The following is a description of a gene set: Mouse Gene Set: REACTOME_NONSENSE_MEDIATED_DECAY_NMD species: Mus musculus Nonsense-Mediated Decay (NMD), and this is the list of marker genes: Rpl35a, Rps14, Ppp2r2a, Rpl27a, Rps8, Rpl15, Fau, Rps15, Rpl30, Pnrc2, Rps15a, Rnps1, Upf1, Rpl7a, Rps19, Rpsa, Rps28, Rps21 (ribosomal protein S21), Ppp2r1a, Eif4a3, Rps2, Rpl28 (NCBI Gene Id 27958), Rps9, Rps26, Rps25, Rpl31, Gspt1, Uba52, Rpl3, Smg7, Gspt2 (NCBI Gene Id 14853), Rps18, Rpl19, Rpl14, Rps27a, Rpl35rt, Gm6525, Rps27l, Rpl4, Rpl12, Rpl22l1, Rpl13, Casc3, Rps4x, Dcp1a, Rpl9, Rbm8a, Rpl27, Rps23, Rps16 (ribosomal protein S16), Rps11, Rps13, Rpl13a, Rplp0, Smg1, Smg8, Rpl11, Rps6, Rpl8, Rpl37a, Rpl18, Rpl34, Upf3b, Rpl23a, Rps20, Rpl6, Rpl37, Rps27, Rpl22, Uba52rt, Rpl36a, Ncbp1, Pabpc1, Rpl24, Rps24, Rpl38, Rps29, Upf2, Rpl36, Magoh, Rps12, Rpl26, Rpl18a, Smg5, Rpl23, Rpl10l (ribosomal protein L10-like), Rps3a1, Rpl35, Rps10, Rps3, Rpl21, Rps27rt, Rpl3l, Rps7, Rpl36al, Ncbp2, Rpl39l, Etf1 (eukaryotic translation termination factor 1), Smg6, Rpl29, Eif4g1, Rpl10-ps3, Rpl36a-ps1, Upf3a, Smg9, Rpl7, Rpl10 (NCBI Gene Id 28147), Ppp2ca, Rpl5, Rps5, Rpl32, Rps17, Rplp2, Rpl17, Rplp1, Rpl39